Given this list of marker genes Aprt, Gmpr, Ampd1, Pfas, Gart, Paics, Ada, Hprt1, Adsl, Atic, Ppat, Gmpr2, Pnp, Ampd3, Ampd2, here is a description of the gene set: The chemical reactions and pathways resulting in the formation of IMP, inosine monophosphate. studied in species Mus musculus Mouse Gene Set: GOBP_IMP_BIOSYNTHETIC_PROCESS